The following is a description of a gene set: from publication Chen Y, Wang X (PMID 31504780) species: Mus musculus Genes predicted to be targets of miRBase v22 microRNA mmu_miR_30c_2_3p in miRDB v6.0 with MirTarget v4 prediction scores > 80 (high confidence targets). Mouse Gene Set: MIR_30C_2_3P, and this is the list of marker genes: Cyb561a3, Ptgir, Dpf2 (double PHD fingers 2), Peli1, Bcat1, Alx4, Ccdc3, Slc35a2, Atp1b4, Prr14l, Abcg4, Ptgdr, Map4k1, Trp53inp2, Dnajb4, Nfia, Frmpd3, Trappc2, Ace2, Mcm7, Endod1, Osbpl7, Entrep2 (endosomal transmembrane epsin interactor 2), Zfp408, Nampt, Slc17a2, Asb15, Acbd6, Acadm, Gatad2b, Sp1, Tshz3, Hmgb2, Fam117a, Sbno1, Ankrd63, Cramp1, Mtarc1, Atxn1l, Spire1 (spire type actin nucleation factor 1), Htra3, Rnf39, Ldlr, C1qtnf3, Ppme1, Rab33b, Shisa7, Prl7b1, Krt31, Tspan18, Ccdc177, Ddx19b, Ednrb, Pde8b, Elk1, Clic5, Cish, Dcaf12, Fem1c, Stx5a, Dpy19l2, Slc8a1, Sesn2 (sestrin 2), Zfp456, Pde6d, Apmap, Foxn1, Rprd1b, Fam221a, Tlk2, Arid4a, Syce2, Krtap13, Dagla, Bbln, Fev, Capn12, Ilk, Cenpq, Cgn, Atp6v0c, Ulk2, Aqp4, Golga7b